The following is a description of a gene set: from publication Johnstone CN, Mongroo PS, Rich AS, Schupp M, Bowser MJ, Delemos AS, Tobias JW, Liu Y, Hannigan GE, Rustgi AK (PMID 17998334) Human Gene Set: JOHNSTONE_PARVB_TARGETS_3_UP Genes up-regulated upon overexpression of PARVB in MDA-MB-231 cells (breast cancer) cultured in 3D Matrigel only. studied in species Homo sapiens Parvin-beta is a focal adhesion protein downregulated in human breast cancer cells. Loss of Parvin-beta contributes to increased integrin-linked kinase activity, cell-matrix adhesion, and invasion through the extracellular matrix in vitro. The effect of ectopic Parvin-beta expression on the transcriptional profile of MDA-MB-231 breast cancer cells, which normally do not express Parvin-beta, was evaluated. Particular emphasis was placed upon propagating MDA-MB-231 breast cancer cells in three-dimensional culture matrices. Interestingly, Parvin-beta reexpression in MDA-MB-231 cells increased the mRNA expression, serine 82 phosphorylation (mediated by CDK9), and activity of the nuclear hormone receptor peroxisome proliferator-activated receptor gamma (PPARgamma), and there was a concomitant increase in lipogenic gene expression as a downstream effector of PPARgamma. Importantly, Parvin-beta suppressed breast cancer growth in vivo, with associated decreased proliferation. These data suggest that Parvin-beta might influence breast cancer progression., and this is the list of marker genes: C15orf39, JUP, SLC25A39, SLC29A2, UACA, LOXL4, ACY1, IRAK2, GABARAP, TTC7B, PITPNM3, PRDX5 (NCBI Gene Id 25824, peroxiredoxin 5), MVP, CTSL, KRT80, KLF6, RNASET2, EPCAM, GDI1, APOL6, TMEM43, PMAIP1, EPAS1, TKT, S100A2, IQGAP1 (NCBI Gene Id 8826), VIPR1, ADGRG1, WDR45, TMC6, DUSP5, F11R, PCBP2, PNMA2, FLNA, GBA1, GAA, DPP7, KCTD2, GOLGA2, KLHL24, PHF10, CD58, PEG10, SH3BP5, LGR4, GLS (NCBI Gene Id 51679), PLBD2, FLII, SEMA4B, S100A16, PPDPF, MELTF, WLS, UNC93B1, P4HB, LRRFIP1, HTRA1, RABAC1, TINF2, CD55, TGM2, HNMT, NAGLU, CLIC3, CTNND1, LIF, HLA-J, WASHC2C, MORC4, CTSB, CSTB, OGA, NAP1L1, TGIF1, FXYD5, MFSD6, PRAG1, NAV1, RBCK1, PTP4A1, MEGF9, CREG1, DENND10P1, SYNGR2, RNF149, ATM, ATP6V0C, TACSTD2, BTN3A3, EHD2, PNRC1, L1CAM (NCBI Gene Id 4268), DAAM1, GFPT2, MYO1C, LDLR, TRIO, SMAD3, AHNAK, SCG2, HLA-DPB1, CSF1, POLD4, ABCC3, TGFBI, CD9, TPRG1L, ABHD17C, ARRB1, TRIB1, LMTK2, MLEC, NTAN1, ZNF703, SEZ6L2, PLIN2, LGALS3BP, PDK4, HLA-G, SULT1C2, LGMN, IGF2R, LPCAT3, ENO2, BTG1, C19orf33, RAB7A, CTSA, ATP2B4, JAK1, THBS1, IKBKB, CA12, GSTK1, PYGB, RETSAT, ITGA2, DIDO1, UGCG, ATG2A, TMEM245, PSMB9, AFDN, TMC8, PARD6B, DDIT4, SPATA20, RETREG3, OSMR, BCL3, ECE1, PPP1R21, MOV10, TOX2 (TOX high mobility group box family member 2), CEBPD, ABCG2, VPS18, CLIP4, PARP12, DNM1, ATP1A1, DAG1, LGALS8, PTGR1, C17orf49, BHLHE40, VAT1, PRXL2A, WIPF2, FRAS1, TNIK, MYO18A, ALDH3B1, PLD1, TIMP2, EFHD2, LOXL2, HINT3, SEC16A, H1-10, TGFBR2, CMTM3, ACLY, VIM, ACADVL, NR2F2, CALD1, PAK2, RIPOR1, VAV2, CAT, KLHL29, ACSL5, APLP2, PLAU, B4GALT5, DDOST, IFI35, HLA-E, VAMP8, GOLGA5, TBC1D9, TNKS2, ACTB, ARFGAP1, SFXN3, SNHG29, PTX3, FAHD1, NBPF14, TMEM87B, ERRFI1, TRIM8, CCND1, HPCAL1, SAMHD1, FN1, PTPN23, PDCD4, SLC17A5, SRPX, LYRM1 (NCBI Gene Id 57149), PLPBP, TNFSF10, GRN, KLF4, KRT19, MKNK2, LRP1, HLA-DPA1, LIPA, NBL1, CEBPB, FAM219A, CYTOR, KMT2A, GCN1, GRK5 (NCBI Gene Id 2869), HLA-F, GLB1, SCNN1A, JAG1, DYNC1H1, BLTP2, SNTB1, FLNB, GATAD1, TANC1, ANXA1, GNS, RCN1, GPR107, NFKBIA, STAT6, BRI3, PRKD2, TOGARAM2, IFITM1, S100A4, CRISPLD2, KLF10, AQP3, DNMBP, NPIPA1, RRAS2, IFITM3, PLPP2, NDFIP1, EMILIN3, TPP1, ESAM, OSBPL3, PRNP, PPFIBP1, SUPT5H, EIF4G1, TIMP1, SYVN1, PSAP, AKR1C3, TAPBP, MAP4 (microtubule associated protein 4), ASXL2, SLC30A1, SLC50A1, PCDHGC3, ARPC1B, TRIOBP, AKR1C1, ITGB4, TAX1BP1, CITED2, VMP1, GSAP, ST3GAL1, FHOD3, PLD3, HS1BP3, PRPF8, RBM47, GBA1LP, FGFR1, SPAG4, EHD1, COL18A1, DNAH2, CALHM2, SPTBN1, RELA, SNX19, ARAF, TLR4, MGST1, NEAT1, SMURF1, ANAPC5, ECH1, MAP2K3, TNIP1, TM7SF2, CDC42EP4, NLRC5, CLU, NANOS1, ATL1, SGK3, C6orf120, NR1H3, PTPRE, HLA-DRA, CELSR1, ICAM1, PLAAT3, PDP1, SFR1 (NCBI Gene Id 119392), STEAP3, DVL2, CST3, AGRN, HMOX1, HLA-DRB1, CALM1, SQSTM1, GSN, NT5DC1, R3HDM4, DMBT1, CD276 (CD276 molecule), LIPG (NCBI Gene Id 9388), AREG, MGAT4B, SIK3, CDK15, POMGNT1 (protein O-linked mannose N-acetylglucosaminyltransferase 1 (beta 1,2-)), MICAL2, NFE2L1, TTC8, HUWE1, STX16, HLA-B, SARDH, LTBP3, OPTN, THBD, CTSD, MMP24OS, CCDC3, ERLIN2, ARHGAP5, PBXIP1, RAPGEF1, C1S, TXNIP, CRTAP, FADS1, BCL9L, ASAH1, AHNAK2, ATXN7, SEPTIN9, PPP1R26-AS1, CPD, SCD, LEPROT, C3, ADD3, MYH9 (myosin heavy chain 9), TMEM135, PYGL, FUT8, RNASE2, CCDC69, RHOB, ABHD12, HLA-DMA, MTA1, MPI, HELZ2, CDC42EP2, ACSL1, LITAF, CDCP1, ORAI3, ALDH3A2, MYOF, ELOVL6, H2AJ, TCIRG1, HTATIP2, ARL4C, FNTA, DSP, TBC1D3F, NPC2, SUPT6H, ARHGAP26, MARCKS, CTSS, ABHD14B, ARNT2, KIF3B, TNFAIP2, HSD17B4, RETREG2, CAPN1, CLDN4, ANXA4, NOTCH2, FLOT2, NOP53, CAPRIN1, MDFIC